Given this list of marker genes CDC42EP1, CDC42EP3, CDC42, KIT, CDC42EP5, APC (NCBI Gene Id 324), F2RL1, WASHC1, CDC42EP2, CCL21, CDC42EP4, C15orf62, CCR7, here is a description of the gene set: Human Gene Set: GOBP_POSITIVE_REGULATION_OF_PSEUDOPODIUM_ASSEMBLY Any process that activates or increases the frequency, rate or extent of the assembly of pseudopodia. studied in species Homo sapiens